Given this list of marker genes RUNX1, NCKAP1L, CBFB, RUNX3, LILRB4, here is a description of the gene set: Human Gene Set: GOBP_POSITIVE_REGULATION_OF_CD8_POSITIVE_ALPHA_BETA_T_CELL_DIFFERENTIATION species: Homo sapiens Any process that activates or increases the frequency, rate or extent of CD8-positive, alpha-beta T cell differentiation.